Given this list of marker genes GFAP, SLC7A10 (NCBI Gene Id 83251), SLC1A3, SLC1A1, NTSR1, SLC1A2, here is a description of the gene set: Human Gene Set: GOBP_D_AMINO_ACID_TRANSPORT The directed movement of the D-enantiomer of an amino acid into, out of or within a cell, or between cells, by means of some agent such as a transporter or pore. species: Homo sapiens